The following is a description of a gene set: from publication Yevshin I, Sharipov R, Kolmykov S, Kondrakhin Y, Kolpakov F (PMID 30445619) Human Gene Set: AUTS2_TARGET_GENES Genes containing one or more binding sites for (AUTS2) in their promoter regions (TSS -1000,+100 bp) as identified by GTRD version 20.06 ChIP-seq harmonization. species: Homo sapiens, and this is the list of marker genes: GREB1L, AZIN1, EIF4A1 (NCBI Gene Id 1973), HOXA10-AS, SERTAD4, LINC01411, FOXD1, RPRD2, USP48, GCC2, ATXN7, NOP2 (NCBI Gene Id 4839), EXTL3-AS1, BCL10-AS1, IBA57-DT, SUPT5H, NEUROG1, BCAP29, DONSON, NFIA, PIP4K2A, RPS8, EML6, CDT1, EIF4E, SMPD4, FAM241B, MIR3651, PPP1R12A, PNCK, TRAPPC1, TIMM8A, UGCG, WDSUB1, SVIL, ASB3, SNORD65, NPR3, FANCA, LARP1, ATXN1-AS1, PTPRG, PANTR1, HOXA9, TLCD1, STIM1-AS1, POLR1A, FKTN-AS1, IST1, NDEL1, ARMT1, TRAF3IP2-AS1, ID2, PKM, ZFHX4, TIPARP, MASTL, ZSCAN29, RPL7L1, STN1 (NCBI Gene Id 79991), LIAS, DARS1, MZT2B, PMAIP1, RNU6-920P, TEN1, THAP7-AS1, PHF3, CCDC107, ETV2, OAT, EIF4G1, RMND1, RNF43, CTNNA1-AS1, MACIR, ZDHHC16, BRAP, TUBGCP4, RNF44, C9orf43, CMTR2, MYL12B, REPIN1, SRSF1, TRAF4, ZWINT, ZNF398, MIR4674, STIM1 (NCBI Gene Id 6786), HEXA, RPL26, PARD3, GFRA3, PHF19, HTR7P1, MRPL43, YME1L1, TPRA1, SEC11A, BRCC3, WDR62, GTSF1, CREBL2, NUDCD2, RNF145, HMGN2, RPL4, ASB7, CEP83-DT, HOMER2, MYL12-AS1, PPP1R12A-AS1, COQ6, ZC3H15, TMEM51, ANXA2R-AS1, PTGES3L, POU3F2, NELL2, NAMPT, PRKAA1, TACO1, RHBDD3, TYRP1, CENPQ, GAS1, AKAP8L, PDE5A, SAMD4B, ZNF503, BCRP8, THAP7, APPBP2-DT, WBP1, PAOX, DIP2A, HSF2BP, ZWILCH, IDH1-AS1, DESI2, RFTN1, SYNCRIP, ARRDC3-AS1, DDX21, CTNNA1, NSUN4, RBBP7, CFAP70, HS3ST3B1, VEZT, SFT2D1, TGIF1, ZNF521 (NCBI Gene Id 25925), TRIM37, HOXA10, PARP6, BAHCC1, RNF115, DDB1, ZSCAN26, BCL2L11, CALM2, DDIT4, CMC4, YWHAE, AIRIM, KIFBP, HNRNPK, GSE1 (NCBI Gene Id 23199), RPL5, HIPK1-AS1, RPS19, IDH1, SNORA80B, DUSP6, THOC7, JAGN1, TWNK, CCDC115, DDX55, DST, TMEM132E-DT (NCBI Gene Id 400591), DYRK1A, RAD1, SLIT2, PHACTR2, HSDL2-AS1, GLI3, LDHA, BHLHE40-AS1, INSM1, ID3, ATG12, SLC38A1, NAMPT-AS1 (NCBI Gene Id 128266843), PANK1-AS1, RPS28, RUNDC1, MAT2A, TPRN, ZFAND4, H3-3A, GDAP2, DDX52, FLOT1, CFAP418, S100A10, LRRC8C-DT, RACK1, CNOT7, TLK1, HOXA4, CCBE1, MON2, RPL37, CNIH3, EFHB, NAA38, RNF217-AS1, PDE4D, KIFAP3, PDLIM1, MPV17, SPRING1, XIAP, RSL24D1, DLG4, NR2F1, MAGOH-DT, ABR, COL19A1 (NCBI Gene Id 7950), FOXO3, NRP2, RPS24 (ribosomal protein S24), LMO4, KANSL1, ZNF444, CPLANE1, FER, TMEM11-DT, REV3L, ACOX1, EML4, BACH2, B3GALT4, LCOR, SLCO5A1-AS1, ARRDC3, SIRT5, DDX24, TNRC6C, MAILR, CNTROB (centrobin, centriole duplication and spindle assembly protein), CCNG1, MECOM, KCMF1, HOXB7, FMO5, SUV39H2 (SUV39H2 histone lysine methyltransferase, NCBI Gene Id 79723), CEP83, TMEM30A, PRKAB1, GATA3-AS1, RBM39, CBX3P2, AP1G1, C9orf78 (NCBI Gene Id 51759), GNL3, MXI1, MAPKAPK5-AS1, ZNF26, PPP4R3B, TM7SF3 (NCBI Gene Id 51768), BLOC1S1, CCDC146, SCAND2P, MRPL33, ODAD2, PSPH, TUBB, CDK4, MAN2A2, SMCHD1, NAGK, BAZ2B, VIRMA-DT, MMUT, HERC4, ING2-DT, MYCN, IARS1, ZNF569, GATA3, DDX3X, CDKN1B, PDCD6IP, PTPN4, POLR3A, LINC00649, IGBP1, SMAD6, AKAP8, ATF6, PPM1D, OSGEPL1, SNORD46, MLLT10, MCRS1, MTCP1, MCC, C11orf54, RPL9, CAGE1, MED27, PBRM1, PABPN1, FOXP2, ENSG00000248636, HOXA5, CHST11, HEY2-AS1, B3GALT9, HOXA-AS3, EXOSC1, SMAP2, WDR31, RAMAC, NMT2, SH3YL1, TSPAN31, YAE1-DT, CILK1, SNORA84, RBM15-AS1, SMAD7, MIF4GD, COX5B (NCBI Gene Id 1329), AKAP1, LCA5, HOXB6, UBXN4, EXD1, HOXC-AS2, RASGEF1B, HOXD10, OSGEPL1-AS1, RMRP, GNG12-AS1, ARPC5L, ZNF236, ZNF503-AS2, CAP1, AFF4-DT, HMMR, GLCE, SAFB, PSME4, ZNF804A, JMJD8, FAM161B (NCBI Gene Id 145483), HACD3, CHD2, KIF23-AS1, ITGAV, MIR193BHG, SLC35F5, SPTBN1, TMED2, COMMD3, SNHG4, ANP32E, RERE, NOP56, IGFBP5, ARHGAP12, TLE3, CNOT8, ASCC1, ZNF570, MAP3K12, TBC1D13, MORF4L1, MYO19, TRIM7, MRPL24, CHTOP (chromatin target of PRMT1), SEMA3D, DPYSL3, BMI1, ZNF529, NPTX1, CDH2, ISL1, SLC38A2, UBL7-DT, C15orf61, C15orf39, MDN1, HS3ST3A1, CCDC134, ATXN1, FZD8 (frizzled class receptor 8), MIDN, ZEB1, EWSR1, LINC02934, RUSC1-AS1, TIMM29, SNAP29, ANAPC1, NIFK-AS1, UBAC2, ZNF655, PANK1, AFF4, STK26, HOXB2, LRRC46, RPS4X, ZNF608 (zinc finger protein 608), CBX3, PARP8, ARL6IP4, TLE4, GLA, CCND1, TUBA1B, DNAJA1, HELZ, GCFC2, TARBP2, DAZAP2, ST3GAL5, FGD6, TXNL1, SLC35A2, GCDH, MANBA, FHIP1A-DT, CSE1L-DT, VPS72, PTMA, DNAJB12, SUV39H2-DT, H4C16, ZNF227, TTLL2, SNORD96A, SLC6A8, TTC41P, RNFT2 (ring finger protein, transmembrane 2), ZNF44, PRSS23, TMEM51-AS1, ATOH8, SATB2, CYFIP2, C6orf226, ITGA7, ATP2B1-AS1, KIF4A, H3-3A-DT, SNORD38A, NRSN2-AS1 (NCBI Gene Id 100507459), ATXN2 (ataxin 2), KLHL13, MAPK4, TUBB4B, CHP1, ARHGDIA, HDDC3, SARS2, TMEM132E, LTB4R2, STARD7, GFI1, ZDHHC7, SCAP, FKTN, CEP290, HDGF, EGLN1, CACUL1, MSL2, POP4, NUP133-DT, HOXB-AS1, LRRC1, TMEM11, COX20, TBC1D7, NDOR1, POLR3C, ARHGAP21, KAT6B, HNRNPH2, PIERCE1, APTX, HRK, B4GALT1-AS1, ATP2B1 (ATPase plasma membrane Ca2+ transporting 1), RPS15, ATP5PO, SPRYD4, IDE (insulin degrading enzyme), FOXK2, SSR1, NDUFAF6, CKAP2L, SPATA4, GPANK1, NR3C1, ENSG00000232732, ANAPC4, DST-AS1, SLCO5A1, HSPA9, LRSAM1, FHIP1A, CLPTM1L, TMEM30A-DT, RNF217, MATR3, SERTAD4-AS1, ATE1, NR2F2, RUSC1, PRCP, HEXIM2, SRSF3, KCNK1, HES1, IBA57, ATE1OSP, SLC24A1, CDKN1A, PVT1, IQCH-AS1, ZFP30, FAM185BP, FZD7 (frizzled class receptor 7), HECTD2, HNRNPF, NT5C3B, IER3-AS1, PRSS23-AS1, PTGES3L-AARSD1, ZEB1-AS1 (NCBI Gene Id 220930), SPAG5-AS1, ACADVL, GTPBP3 (GTP binding protein 3, mitochondrial), RNF113A, IMP4 (IMP U3 small nucleolar ribonucleoprotein 4), WDR26, NEK8, MARCHF7, EIF4G2, ZBTB18, XIST, YIPF2, RDX, FKBP9, SET, LIG3, BCR, CDKN2C, WDR7, VPS37A, CDK6, TEN1-CDK3, ZNF345, PFKP (phosphofructokinase, platelet, NCBI Gene Id 5214), ZNF790, ARHGAP15, IGF2BP1, FDXR, AGPAT1 (NCBI Gene Id 84827), DDIAS, CSNK2B, ZNF778-DT, AAK1, ITFG2, LINC02817 (long intergenic non-protein coding RNA 2817, NCBI Gene Id 400804), ETF1, ITFG2-AS1, KCTD15, HES6, TLE6, FAM98A, TOB2, KIAA1958, LRRC8C, GAPDH, POLL, TMEM33, ZNF181, ID2-AS1, TLCD3A, ALOXE3P1, DNM1L, HNRNPDL, OXCT1-AS1, WDR93, GTF3C5, ZFP37, DSTYK, ZMIZ1, CITED2, NRP1, PARD3-DT, PFKFB3, HOXA3, FASN, UQCC6, LINC00923, TMEM203, AP3S1, WBP4, HOXA6, GNAL, FAM120B, UPF1, CCDC183-AS1, TFIP11, INVS, MVP-DT, TFAP2A, TOP2A, PLXDC1, PHF8, MDM2, ING2, MIR1915 (NCBI Gene Id 100302129), MAPKAPK5, CTBP2, PFKFB3-AS1, SNORD38B, HOXC4, LRRC7, BTG1-DT, ZMIZ1-AS1, HEXA-AS1, HIPK1, COG2, NEO1 (neogenin 1)